Given this list of marker genes Terf1, Terf2, Tmbim6, Neil1, Dffa, Gzma, here is a description of the gene set: Any process that stops or reduces the rate of nuclease activity, the hydrolysis of ester linkages within nucleic acids. Mouse Gene Set: GOBP_NEGATIVE_REGULATION_OF_NUCLEASE_ACTIVITY studied in species Mus musculus